Given this list of marker genes SMAD6, STRA6, ADAMTS5, ROBO2, HEY1, HEY2, TBX20, JAG1, SMAD2, ROBO1, SLIT2, NOS3, NOTCH2, TGFB2 (NCBI Gene Id 7042), BMP4, NOTCH1, GJA5, ADAMTS19, HEYL, NFATC1, here is a description of the gene set: The process in which the structure of the pulmonary valve is generated and organized. species: Homo sapiens Human Gene Set: GOBP_PULMONARY_VALVE_MORPHOGENESIS